The following is a description of a gene set: Human Gene Set: HP_FLARED_METAPHYSIS Flared metaphysis The presence of a splayed (i.e.,flared) metaphyseal segment of one or more long bones. species: Homo sapiens, and this is the list of marker genes: COMP, TCIRG1, CCN2, PTDSS1, NPR2, XYLT1, POLR1A (RNA polymerase I subunit A), OSTM1, DDR2, KIF22, FLNA, RUNX2, PCYT1A, NEK1, TRPV4 (NCBI Gene Id 8098), SLC39A13, PTH1R, MMP13, B4GALT7, DNA2, EZH2, ERCC1, DDRGK1, RMRP, MAP3K7, TAPT1 (NCBI Gene Id 202018), IARS2, CYP3A4, COG4, ALG9, GSC, CHST3, COL10A1, NANS, PCNT, ANKH (ANKH inorganic pyrophosphate transport regulator), COL2A1 (collagen type II alpha 1 chain), AXIN1, EED, LBR (lamin B receptor), VAC14, FIG4, FGFR3, TONSL (NCBI Gene Id 4796), GJA1, FAM111A, LIFR, COL11A2, B3GALT6, PRKG2, PEX7, B3GAT3 (NCBI Gene Id 26229), SH3PXD2B